The following is a description of a gene set: Genes having at least one occurrence of the motif NAWTTCYNGGAAWTN in the regions spanning 4 kb centered on their transcription starting sites. This matches the STAT5B transcription factor binding site V$STAT5B_01 (v7.4 TRANSFAC). studied in species Homo sapiens Human Gene Set: STAT5B_01, and this is the list of marker genes: STC1, GRB10, AKT1, MAFF, DTX2, CHN2, AP1G2 (adaptor related protein complex 1 subunit gamma 2), NR4A3, SCRG1, XRCC1, ARF3, FUT8, LAMA2, SLAMF1, LCP2, MAPK10, F9, PMCH, CXCL11, LINC00656, AGRP, FGA, NR4A2, TMUB2, PHF21B, FXYD1, CSN3, MASP2, FAP, PLEC, PHC1, SLC26A9, PSD, PCOLCE, PRKAR2B, TAL1, SDHAF2, HJV, USP25, RARA, ZNF235, HAMP, LAPTM4B, ETV5, ZNF233, CNRIP1, BEND4, AP2M1, SOD1, DGKA, CEP41, PRR5L, ZYX (NCBI Gene Id 7791), ECEL1, TSPAN6, SDC1, LIX1, TRIM55, APBB1, FST, SHISA6, MSX1, TMEM208, GK, NEK6, SLCO1B1, FOS, BBS1, WIPF1, NDST1, MARCHF10, BET1, ERG, TRIM25, CPSF7, BMP5, CMTM6, LIF, ZNF423, MTTP, PVALB, PLAGL1, INPP5F, PPARD, TLX2, MAP4K4, SLC38A5, MECP2, MGAT4C, KCNN3, NTF4, ADAMTSL3 (ADAMTS like 3), ICAM1, HOMER2, TUT1, SOCS2, ADAMTS4, HTRA2, SMC4, OIT3, COQ8B, CCL2, HNRNPR, DYNC2LI1, TMEM60, POLR2M, WNT10A, NCALD, CCDC25, CXCR5, C1QTNF1, BCL6, KCNJ8, CBLIF, TRIM15, SPMIP6, MRPL24, LINC00314, ARID1A, NOB1, TMEM100, PCDH1, EDEM2, RBM14, CORT, VIP, TMLHE, GMPPB, BCL9, ADAM11, ZNF180, PROS1, POU4F1, NRP1, RRAS, SEC24C, BRINP3, TCEA2, PTCHD4, CSN1S1, TSPAN4, DLL4, NFKBIA, HCN4, TSHZ2, SNCB, IFT43, TLR7, APBA1, SYNPO, CDH1, CERT1, TWIST1 (twist family bHLH transcription factor 1), ARHGAP36, PLSCR1, CYP26A1 (cytochrome P450 family 26 subfamily A member 1), KLF4, DIS3L, OLFML3, PDLIM1, CFAP65, TLX3, ZNF112, LSAMP, PI4K2A, NRXN3, ASXL1, ATP11C, AMBN, ZNF582, SYMPK, IRF2, DLX4, MAP2K3, OGG1, ADAMTS6, SRPX, IRF8, PPARGC1B (PPARG coactivator 1 beta), FRMD6 (NCBI Gene Id 122786), C7, ATP5PD, AZI2, LINC00652, VTN, ANK3 (ankyrin 3), BDNF, PALLD, CLU, AJUBA (NCBI Gene Id 84962), TMEM74B, PLA2G3, IRF9, CCL5, CREM, ADAMTS9, IFTAP, GSK3A, MIR17HG, TNFSF11, BTK (Bruton tyrosine kinase), TRIM46, CISH, PCSK2, CLEC1B, MXD1 (NCBI Gene Id 4084), CLDN5, IGFALS, CD40LG, DOCK4, TMOD3, IRF4, OSM, ELL, NDUFS2, GLRA2, HOXA2, KLF9, NT5C2, S100A3, NFIL3, PHOX2B, PAN2 (poly(A) specific ribonuclease subunit PAN2), ZEB2, IFT80, KRTCAP2, RESF1, LAMA1, PLPP6 (phospholipid phosphatase 6), DRC7, ITPKC, TSPAN31, HOXA3, TNS2 (NCBI Gene Id 23371), CLDN8 (claudin 8), PRDM1, VASN (NCBI Gene Id 337957), PROK1, SERPING1, RAB11B, AUP1, ARIH1, SMPD1, BATF, LEP, DISP2, CREBRF, CEBPG, ARHGEF39, POLDIP3, GPATCH4, ENPP2, EXPH5, IRF1, FOXA3